The following is a description of a gene set: Human Gene Set: GOBP_VESICLE_DOCKING_INVOLVED_IN_EXOCYTOSIS species: Homo sapiens The initial attachment of a vesicle membrane to a target membrane, mediated by proteins protruding from the membrane of the vesicle and the target membrane, that contributes to exocytosis., and this is the list of marker genes: PPFIA3, EXOC7 (NCBI Gene Id 23265), UNC13C, VPS18, UNC13B, RIMS3, EXOC2, RAB8A, CPLX2, UNC13A, STXBP3, CFTR, GNAO1, BLOC1S6, STX1B, STXBP1, EXOC5, VAMP3, SYTL2, RIMS2 (regulating synaptic membrane exocytosis 2), RALB, EXOC3, SNPH, PLEK, EXOC6, EXOC1, KCNB1, TPRG1L, EXOC6B, RABEPK, EXOC8, YKT6, VTI1B, STX1A (NCBI Gene Id 6804), SNAP25, STXBP2, VPS11, EXOC4, RIMS1